The following is a description of a gene set: The series of molecular signals mediated by hypoxia-inducible factor (HIF1) in response to lowered oxygen levels (hypoxia). Under hypoxic conditions, the oxygen-sensitive alpha-subunit of hypoxia-inducible factor (HIF)-1 dimerizes with a HIF1-beta subunit (also called ARNT or aryl-hydrocarbon-receptor nuclear translocator), translocates to the nucleus and activates transcription of genes whose products participate in responding to hypoxia. species: Homo sapiens Human Gene Set: GOBP_HYPOXIA_INDUCIBLE_FACTOR_1ALPHA_SIGNALING_PATHWAY, and this is the list of marker genes: PDK3, RWDD3, HIF1A, EGLN1 (NCBI Gene Id 54703), PDK1, CYBB, MIR210, COMMD1